The following is a description of a gene set: species: Homo sapiens from publication Mata-Haro V, Cekic C, Martin M, Chilton PM, Casella CR, Mitchell TC (PMID 17569868) Human Gene Set: GSE7768_OVA_ALONE_VS_OVA_WITH_MPL_IMMUNIZED_MOUSE_WHOLE_SPLEEN_6H_UP An unresolved issue in immunology is the extent to which inflammatory effects are needed for robust T cell responses. In this study, mice were immunized by iv injection using either high toxicity lipopolysaccharide (LPS) or low toxicity monophosphoryl lipid A (MPL) as adjuvant. Six hours after iv immunization, whole spleens were harvested and gene expression was measured in unfractionated splenic populations of cells. The analysis indicated that the low toxicity adjuvanticity of MPL was associated with TLR4-mediated signaling that was biased to the TRIF branch of TLR4, while LPS generated balanced MyD88 and TRIF-associated outcomes. Genes up-regulated in spleens from mice immunized with ova peptides alone versus those immunized with monophosphoryl lipid A as adjuvant., and this is the list of marker genes: HDAC5, IDH3B, POLR3D, TLCD1, OTUD7B, OXR1, PPM1G, STXBP5, TPCN2, PABPN1, DNPEP, NBN (nibrin), BUB1B, CRAT, PHKA2, RBM15, PFAS, TRERF1, MLH3, NCAPD2, PYGB, TSSC4, NAT9, SLC37A2, TBC1D10A, RAB31, KIF24, MTMR10, CEP120, KIF23, SLC20A1, HELLS, BRCA2 (BRCA2 DNA repair associated), FANCE, SESN1, ZMYM2, TK1, OSTM1, KCNE3, CENPC, SLC25A13, PLEKHG3, POC1B, RDH13, PHF2, MCRIP2, GET1, MRPS31, RBL2, AP3D1, GMNN, EZH2, MEF2C, HDAC10, XYLB, PRDM15, CNBP, ATAD5, HIP1, NLRC3, FASN, LRP12, RAB3IL1, XK, TOP1MT, REEP4, FNBP1 (formin binding protein 1), NR6A1, MBP, SMAD3, PHF3, RNF150 (ring finger protein 150), AURKA, TIAL1 (NCBI Gene Id 8430), CRY1, CDC20, RALGAPB, CDKN2C, ABL1, SKA2P1, LAT2, SRL, KIF18B, SLC38A2, NIFK, HROB, SQLE, GAK, CDCA8, NCAPH, ACOX3 (acyl-CoA oxidase 3, pristanoyl), RNF13, NUP205, EFL1, MCPH1, TROAP, RETREG3, NEMP2, THAP11, KCNJ2, WDR91, TTLL4, IDH2, NT5C2, TMEM218, TBC1D4, URB1, SLX4, SLF2, NLRX1, GAN, CSE1L, ASXL1, CIT, TGFBR1, SKP2, ANLN, MRPL49, PLK1, TRUB2, SMC3, CEP43, CTBP1, SLC41A3, OSBPL2, FBXO31, TBC1D22A, TBL1XR1, HDAC9, POLH, INPP5D, PALS1, ELOVL6, CDCA2, KLC1, C2CD2, SET, SLC29A2, POLRMT, B3GNT8, SAFB2, FRMD6, H2BC14, MYO7A, CDCA4, UBR2, EIF4G1, OTULINL, ACLY, FHOD1, MFHAS1, KNL1, SNX8, ZDHHC14, QSER1, ZRANB3, ZSWIM4, OAT, PNKP, KYAT1, ARL4C, FAM83D, PANK1, CARD9 (NCBI Gene Id 64170), UHRF2, ETV5, MTSS1, CENPN, LACTB, SLC5A3, TRPS1, ING1, PKP4, ACO1, VCP, USP20, SUSD3, JOSD1 (Josephin domain containing 1), ECT2, PIK3CB, CCNA2